Given this list of marker genes Cfap418, Mab21l3, Nadk2, Coq7, Kcnn3, Adam1b, Tspan4, Prr15, Serpinb1a, Zfr, Ctcfl, Golt1a, Fosl2 (fos-like antigen 2), Tead1, Gch1, Hacd3, Snap25, Yaf2, Rab33b, Fzd4, Dnm3, Masp2 (NCBI Gene Id 17175), As3mt, Tox3, Lipt2, Kcnj6, Cadm2, Mob3c, Got1, Mup13, Ssbp3, Zeb2, Kif3b, Prss3b, Fut9, Mup1, Cdc42ep4, Tmem252, Slco1a1, Ankrd49, Plekha3, Mup8, here is a description of the gene set: Mouse Gene Set: MIR_1933_5P Genes predicted to be targets of miRBase v22 microRNA mmu_miR_1933_5p in miRDB v6.0 with MirTarget v4 prediction scores > 80 (high confidence targets). studied in species Mus musculus from publication Chen Y, Wang X (PMID 31504780)